The following is a description of a gene set: Reactome Pathway: Formation of the posterior neural plate studied in species Homo sapiens part of: Gastrulation The neural plate is a thickened layer of cells on the dorsal surface of the gastrula rostral to the node and primitive streak. As development proceeds, the neural plate folds to form a tube that will generate the brain and spinal cord. Failure to completely form a neural tube causes neural tube defects, such as spina bifida, which are the most common birth anomaly of the central nervous system. Though a single structure, the neural plate actually contains two regions formed from different progenitors and regulated by distinct gene expression programs: the anterior neural plate (ANP) gives rise to the forebrain and midbrain and the posterior neural plate (PNP) gives rise to the hindbrain and anterior part of the spinal cord.<br>The ANP arises directly from the epiblast, requires inhibition of BMP signaling by secreted inhibitors from the anterior visceral endoderm (reviwed in Andoniadou and Martinez-Barbera 2013), and expresses SOX2 driven by OTX2, ZIC2, and POU5F1/POU3F1 bound to the N2 enhancer upstream of the SOX2 gene (inferred from mouse homologs in Iwafuchi-Doi et al. 2012). The posterior part of the PNP arises from neuromesodermal cells that express SOX2 driven by WNT and FGF acting through the N1 enhancer downstream of the SOX2 gene (inferred from mouse homologs in Takemoto et al. 2006).<br>Both the ANP and PNP express ZEB2 and SOX1, however the ANP is characterized by high OTX2 expression, while the anterior PNP expresses higher levels of GBX2 (inferred from mouse homologs in Simeone et al. 1992). The boundary between the ANP and the PNP is partly determined by a mutual antagonism between OTX2 and GBX2. OTX2 from the ANP represses expression of GBX2 and GBX2 from the PNP represses expression of OTX2 (inferred from mouse homologs in Wassarman et al. 1997, Martinez‑Barbera et al. 2001, Li et al. 2001)., and this is the list of marker genes: FGF8, ZEB2, GBX2, SOX2, WNT3A, POU3F1, ZNF521, TBX6, OTX2, SOX1 (NCBI Gene Id 6656)